Given this list of marker genes FUT6, FUT7, FUT4, FUT2, B3GALT4 (beta-1,3-galactosyltransferase 4), ST3GAL4, B3GALT1, ST6GALNAC6, B3GALT2, FUT9, ST3GAL3, B3GALT5, ST3GAL6, B4GALNT2, FUT5, FUT3, here is a description of the gene set: part of: Blood group systems biosynthesis Reactome Pathway: Lewis blood group biosynthesis studied in species Homo sapiens The Lewis antigen system is a human blood group system based upon genes on chromosome 19 p13.3 (the <i>FUT3</i> gene aka the <i>Le</i> gene) and 19q13.3, (<i>FUT2</i> gene aka the <i>Se</i> gene). Both genes are expressed in glandular epithelia and have dominant alleles (Le and Se, respectively) coding for enzymes with fucosyltransferase activity and recessive alleles (le and se, respectively) that are non-functional. There are two main Lewis antigens, Lewis A and Lewis B which can result in three common phenotypes: Le(A+B-), Le(A-B+) and Le(A-B-). Lewis antigens are components of exocrine epithelial secretions, and can be adsorbed onto the surfaces of red blood cells (RBCs), therefore are not produced directly by RBCs themselves (Ewald & Sumner 2016).<br><br>The same two oligosaccharides (Type 1 and Type 2) used to determine ABO blood types are also utilised by the Lewis system. Fucosyltransferase 3 (FUT3, Le) adds fucose to Type 1 chains to form the Lewis A antigen (LeA). IF the individual is a non-secretor (lacks the Se gene, homozygous sese), LeA is adsorbed onto the red cell, and that individual is LeA type. Approximately 80% of the population has the <i>Se</i> gene. Functional fucosyltransferase 2 (FUT2, Se) adds a fucose to LeA to form LeB. Both LeA and LeB present in the plasma of secretors but LeA preferentially adsorbs onto the RBC and therefore, the individual types as LeB. Other FUTs, especially FUT4, can add a fucose to Type 2 chains to form the Lewis X antigen (LeX). Further fucosylation of LeX by FUT2 produces the Lewis Y antigen (LeY). LeX and LeY are structural isomers of LeA and LeB. The formation of LeY is controlled by Se/se as in the case for LeB. LeA and LeX antigens can also undergo sialation to produce sialated forms of these antigens.<br><br>Aberrant glycosylation of tumour cells is recognised as a feature of cancer pathogenesis. Overexpression of fucosylated and sialated Lewis antigens frequently occurs on the surfaces of cancer cells and is mainly attributed to upregulated expression of the relevant fucosyltransferases (FUTs). The sialyl-Lewis A antigen (sLeA), also known as the CA19-9 antigen, is the most common tumour marker used primarily in the management of pancreatic and gastrointestinal cancers worldwide.<br><br>Selectins (L-, E- and P-selectin) are type I membrane proteins composed of long N-terminus C-type lectin domains protruding into the extracellular space and with a short cytoplasmic tail. They bind carbohydrate structures through a Ca2+-dependent domain, the minimal sugar structure recognised fulfilled by sLeA and sLeX. Selectins are found on endothelial cells, platelets and leukocytes and are involved in trafficking of cells of the innate immune system, T lymphocytes and platelets, thereby playing important roles in chronic and acute inflammation and haemostasis. Selectins also play a role in cancer progression. Metastasis is facilitated by cell-cell interactions between cancer cells and endothelial cells in distant tissues. In addition, cancer cell interactions with platelets and leukocytes contribute to cancer cell adhesion, extravasation, and the establishment of metastatic lesions. Targeting selectins and their ligands as well as the enzymes involved in their generation, in particular sialyl transferases, could be a useful strategy in cancer treatment.